The following is a description of a gene set: studied in species Homo sapiens Human Gene Set: GOBP_NEGATIVE_REGULATION_OF_COLLAGEN_METABOLIC_PROCESS Any process that decreases the frequency, rate or extent of the chemical reactions and pathways resulting in the metabolism of collagen, any of a group of fibrous proteins of very high tensile strength that form the main component of connective tissue in animals., and this is the list of marker genes: MIR29A, ERRFI1, PPARD, IL6R, MIR29B1, CIITA, NOTCH1, IL6, CYGB, RAP1A, MIR92A1, MIR218-1, CST3, CYP7A1, EMILIN1, GOT1, NPPC